The following is a description of a gene set: studied in species Homo sapiens from publication Konuma T, Nakamura S, Miyagi S, Negishi M, Chiba T, Oguro H, Yuan J, Mochizuki-Kashio M, Ichikawa H, Miyoshi H, Vidal M, Iwama A (PMID 21540074) Human Gene Set: GSE27786_LSK_VS_MONO_MAC_UP Genes up-regulated in comparison of LSK versus monocyte macrophages. Each fraction of mouse hematopoietic cells was purified by cell sorting from bone marrow of 8-week-old C57BL/6 mice, and its gene expression was analyzed., and this is the list of marker genes: RETSAT, HMG20A, COMMD7, THAP12, ZBTB20, RBM22, IPO11, CANX, OTULIN, HLA-DOA, DENND1A, HYPK, SLC43A1, COA8 (cytochrome c oxidase assembly factor 8), FPGS, PRKDC, CHD9, SELENBP1, CCT2, UBR7, FAM135A, AJUBA, PDK1, URI1, ITPR3, FH, PES1, FAHD2A, DHRS4, ATPAF1, UQCR11, GYPC, EARS2, CIPC, C1orf122, ZBTB45, POLR3K, EDC3, SF3A3, RCC1L, PSMA4, PRODH, XIST, PPFIA1, RUVBL2, RSL24D1, SCMH1, ENOX2, TUBB1, MICU3 (mitochondrial calcium uptake family member 3), NDUFAF4, PEX14, ZNF280C, NUP155, GPATCH2, DIABLO, PUS3, GRPEL2, RIPPLY3, TBC1D32, CHST14, MYEF2, ATP5F1B, EXOC4, CTSF, HOOK1, MZT2B (NCBI Gene Id 80097), IMMP1L, RRP1, IVD, RASGEF1B, RPS26, PKD2, RPL22L1, EIF2B4, TRMT112, XRCC5, CDC23, CPSF1, SNX5, SEPTIN6 (NCBI Gene Id 23157), UBFD1, CCDC86, ETNK1, AGO1, MLH1, SNHG6, PI4K2B (phosphatidylinositol 4-kinase type 2 beta), TOPBP1, GLRX5, PHF14, FBXO31, ZNF704, SLC29A1, POLD1, CDC5L, ABCB6, SGCB, KMT2A, STAU2, GPN3, GCN1, TAF3, SSR2, SIPA1L1, DOHH, LRWD1, TPI1, COASY, NAA10 (NCBI Gene Id 8260), ITFG2, SNRNP25, TRIM44, STRAP, KCNQ1OT1, ZNF251, VPS16, DTYMK, RPUSD1, BBS10, QSOX2, ZSWIM7 (zinc finger SWIM-type containing 7), MED22, ZNF319, FBXL6, GUF1, TFPI, TCP1, RAMP1, PRKCQ, ARHGAP18, ZDHHC13, JAGN1, TNS1, FIRRE, KDM1A, SERBP1, BANF1, DDX46, MARCHF5, IFT74, AP1AR, MRPS25, OAT, CUL9, RBM48, FARP2, PNPT1, CD96, CEP83-DT, PPIL3, C12orf75, MTG1, EIF2B2, LARGE2, FASTKD5, TOM1L2, LSS (NCBI Gene Id 4047), CCT6A, RPAIN, ZNF569, RRP9, FBXW8, TFB1M, PRPF40B, ERCC5, NUP214, CHD6, SRR, PRPF6, HDAC6, GAB1, SLC25A23, KIFAP3, AKR7A2, BPNT2, ABRAXAS1, CA9, AK4, B3GLCT, PACRGL, TSHZ1, CFAP97, CLEC1A, ALG2, SLF2, MPLKIP, MAPK1, HUWE1, ALKBH7, RRAD, CLYBL, NTPCR, SDHAF1, NXF1, IL7, PSMD12, TP53BP1, C8orf82, RNF220